Given this list of marker genes MAPK7, TCTN1, MRPS31, GJB5, MTPAP, CBLB, CYP1A1, OR7A17, CD84, RASL11B, ZNF471, SLC14A1, OGFRL1, DGKB, TXN, LHX5, HLA-DQB1, IRX4, ZBTB17, KCNK5, LTBP1, SDC4, MT1G, MEST, FABP7, ANKS1B, MFSD6, CPB1, HRH4, RGS4, CSN2, UBL3, CSRNP2, PNRC1, RBPJ, CFAP46, TAGLN3, ADAMTS3, CPA4, SLC25A32, CYB5R1, TTYH1, NEUROD1 (neuronal differentiation 1), LDAH (lipid droplet associated hydrolase), RYK, LYPD3, CD200, TARP, KIT, ULK1, TNFRSF1B, AHI1, NFKB2 (NCBI Gene Id 4791), RPLP2 (ribosomal protein lateral stalk subunit P2), CTSF, ECM2, MYG1, GSTZ1, PAK5, CCL5, CANX, PDIA6, LRRC42, PPARD, ENPP2, KIAA0513, SLC7A10, TMOD2, STEAP4, CETN1, LYPD1, NUS1P3, GLS, HPSE, FOSL1, CARD10, ARAP3, EXO1, SEMA4D, PRR4, STX17, CYP4F11, NBL1, NKX6-1, HEXIM1, HCCS (holocytochrome c synthase), TRMT5, HBB, STX18, PRKCH, CEACAM1 (NCBI Gene Id 634), PTPRG, DKK2, RXFP3, DIS3, PPP6C, MERTK, MTARC2, PMM2, WDR45B (NCBI Gene Id 56270), PSENEN, ZNF287, SFMBT1, CEBPD, COMMD3, RORA, FLJ13224, SORT1, ST7L, SLC39A14, CPM, ADIPOR2, WDR48, SLC12A2, DESI1, MRPL39, PHF10, DPYSL4, HBP1, KDM5B, SOBP, CEBPB, ARHGAP25, BICD1, PKP2, CLDN14, VPS41, SCHIP1, FBXO21, SERINC2, CD14, TEKT2, WBP11, NGDN (NCBI Gene Id 338007), SMOX, KIF25, DSTYK, POLR3E, AQP2, RNF121, DLC1, CRISPLD2, DOT1L, CLDN15, PPP1R16B, LCN1 (NCBI Gene Id 82904), TFF1 (NCBI Gene Id 7031), ME1, AKAP4, DOP1A (NCBI Gene Id 285787), RUNDC3B, ENG, REL, IFNA8, FOXA2, CAAP1, TPBG, SLC6A16, BTBD7, MAGT1, PMF1, ADAMTS8, VIP, USP53, BAHD1, H2BC8, CCR2, UGT2B4, PCBP3, ASCC1, RBMS2 (RNA binding motif single stranded interacting protein 2), UTP14C, ZSCAN5A, TXNRD1, CEMIP, PDK3, FBN2, STK4, NINJ1, BATF, HOXD3, PSG3, HNRNPC (heterogeneous nuclear ribonucleoprotein C), MAL, ITIH3, GYPE, RPA3, ERCC6, PRDX1, IL19, BEAN1, GNG4, HMOX1, SRPX2, CHMP1B (charged multivesicular body protein 1B), OTULINL, GPALPP1, PDIA3, here is a description of the gene set: Genes up-regulated in CD4 T cells: tretinoin versus Ro 41-5253. studied in species Homo sapiens from publication Kang SG, Park J, Cho JY, Ulrich B, Kim CH (PMID 20664575) Human Gene Set: GSE20500_RETINOIC_ACID_VS_RARA_ANTAGONIST_TREATED_CD4_TCELL_UP This is to determine the T cell genes regulated by retinoic acid.